Given this list of marker genes CSF1, GNG12, PSMA5, FZD10, CMAHP, SLC35D2, MARS1, SLC35F6, ADAMTS9, RRM1, CHST3, SKA1, VPS13B, AFM, ARR3, TNFAIP2, GPR107, RER1, ADAMTS3, ECM2, ALG5 (ALG5 dolichyl-phosphate beta-glucosyltransferase), NCAM2, ID2, MED21, PRRC2C, PLEKHO1, GOLM1, GSK3B, ZBTB44, UGT2A3, OVGP1, GPR171, ABCF2, NPVF, HSPA6, CCZ1B, PVT1, PLAGL2, ETF1, ALOX15B, CTSK, INA, DNAJC6, SCRN3, THSD7A, MORC2, GLS, PLAC1, RLN2, SIDT2, FSCN3, SEMA6D, CEACAM7 (CEA cell adhesion molecule 7), FCRL2, ADGRB2, PNN, LINC01711, DENND2A, SNRPD1, LPCAT4, TBX1, EFR3B, LY6G6D, SPATA2, ARHGEF7, PPP1R10, ACSF2, GPR182, ELK4, PAPOLA, GADD45G, CENPB, MTMR11, RRAS2, SSBP1, HBEGF, BCL2L1, RAD54L2, RSAD1, CTTN, HOXD11, SCNN1D, PAX9, GJC1, MGAT1, MATCAP2, ABTB2, TASOR, JMJD4, PHTF2, DNAH3, HOXB1, SLC2A6, TM4SF20, RFC3, PREX2, CYB5R3, TEK, PIPOX, TRAF4, WDR4, BTN3A3, CCT4, CTSW, PIP4K2B, VCP, PSMD14, CRHR2, YWHAB, KDM4B, CCDC68, CRTAP, FBXW11, CDO1, CHEK1, AGRP, GDF2, IKZF3, KCNC3, ASCL3, CETP, H2AC17, NSD3, CRLF2, ELF3, AP1S1, RANBP17, SDC2, RORA, TGFBR3, NLRP2, FAM50B, GJC2, CHRNA3, POLR3F, EXOSC2, FHL5 (four and a half LIM domains 5), ZNF764, JAKMIP2, GFAP, NPY6R, COL4A5, CHRNA1, TMEM9B, GDI2, ATP2A2, KCNMB1, STX5, PAFAH1B3, SLC17A4, JUNB, CYP21A2 (cytochrome P450 family 21 subfamily A member 2), PRMT1, DHRS3, OGG1 (NCBI Gene Id 93577), DDX54, ENTREP1, ZNF337, GAD1, HECTD3 (HECT domain E3 ubiquitin protein ligase 3), LSS, SPHK2, KLRC3, AKAP8, CEPT1, RNF34, COX4I1 (cytochrome c oxidase subunit 4I1), NME5, RGS12, TRIP4, WWC1, URB1, RFX5, TIMM17B, BTN2A1 (butyrophilin subfamily 2 member A1), ACTR1B, UTS2, MCM6, FDFT1, JPH3, OPA1 (NCBI Gene Id 4976), RLBP1, TIPIN, CDH2, BAZ1A, TRABD, ELF2, HNF1B, KLHL35, APOC1, UMPS, NRG1, ATG2B, MRPL34 (mitochondrial ribosomal protein L34), TFIP11, PSMC3IP, here is a description of the gene set: from publication Walmsley SR, Chilvers ER, Thompson AA, Vaughan K, Marriott HM, Parker LC, Shaw G, Parmar S, Schneider M, Sabroe I, Dockrell DH, Milo M, Taylor CT, Johnson RS, Pugh CW, Ratcliffe PJ, Maxwell PH, Carmeliet P, Whyte MK (PMID 21317538) Human Gene Set: GSE26023_PHD3_KO_VS_WT_NEUTROPHIL_HYPOXIA_DN Neutrophils were isolated form peripheral blood of wildtype and Phd3 null mice, cultured for 4 hours in hypoxia (3% O2) and micro array analysis performed The aim of the present study is to identify the mechanism by which phd3 is required for the hypoxia mediated survival of neutrophils Genes down-regulated in neutrophils under hypoxia: EGLN3 knockout versus wildtype. studied in species Homo sapiens